Given this list of marker genes SHH, JUP, TARDBP, TRIM28, ECT2, RBM22, HDAC3, ZC3H12A, HYAL2, CDK1, PRKCD, PIK3R2, PRKD1, PIK3R1, IFNG, GLI3, HSP90AA1, CDH1, ZPR1, MAPK14, LEP, JAK2, PSEN1, UBR5, IPO5, HCLS1, XBP1, TGFB1, EFCAB7, EP300, SMAD3, BAG3, TPR, RAN, SMO, DMAP1, FLNA, MAVS, ZIC1 (Zic family member 1), CHP2, here is a description of the gene set: species: Homo sapiens Any process that activates or increases the frequency, rate or extent of movement of proteins from the cytoplasm into the nucleus. Human Gene Set: GOBP_POSITIVE_REGULATION_OF_PROTEIN_IMPORT_INTO_NUCLEUS